Given this list of marker genes MASP1, COLEC10, TBX15, SH3PXD2B, COLEC11, TAF1, here is a description of the gene set: Human Gene Set: HP_PROMINENT_COCCYX studied in species Homo sapiens Prominent coccyx